The following is a description of a gene set: Dopaminergic neurogenesis Human Gene Set: WP_DOPAMINERGIC_NEUROGENESIS studied in species Homo sapiens, and this is the list of marker genes: LMX1A, EN1, EN2, TH, SOX2, DDC, GLI1, NKX2-2, FGF8, LMX1B, GLI2, NR4A2, PITX3, SLC6A3, WNT1, MSX1, ASCL1, NEUROG2, TGFB1, SLC18A2, OTX2, NEUROD1, RET, STAT3, ALDH1A1 (NCBI Gene Id 96075), FOXA2, SHH, NKX6-1, GBX2, CDKN1C